The following is a description of a gene set: Examples of transcription factors whose activities are regulated by MAPK14 phosphorylation. from publication Turjanski AG, Vaqué JP, Gutkind JS (PMID 17496919) species: Homo sapiens Human Gene Set: TURJANSKI_MAPK14_TARGETS The mitogen-activated protein kinases (MAPKs) are a family of serine/threonine kinases that play an essential role in signal transduction by modulating gene transcription in the nucleus in response to changes in the cellular environment. They include the extracellular signal-regulated protein kinases (ERK1 and ERK2); c-Jun N-terminal kinases (JNK1, JNK2, JNK3); p38s (p38alpha, p38beta, p38gamma, p38delta) and ERK5. The molecular events in which MAPKs function can be separated in discrete and yet interrelated steps: activation of the MAPK by their upstream kinases, changes in the subcellular localization of MAPKs, and recognition, binding and phosphorylation of MAPK downstream targets. The resulting pattern of gene expression will ultimately depend on the integration of the combinatorial signals provided by the temporal activation of each group of MAPKs. This review will focus on how the specificity of signal transmission by MAPKs is achieved by scaffolding molecules and by the presence of structural motifs in MAPKs that are dynamically regulated by phosphorylation and protein-protein interactions. We discuss also how MAPKs recognize and phosphorylate their target nuclear proteins, including transcription factors, co-activators and repressors and chromatin-remodeling molecules, thereby affecting an intricate balance of nuclear regulatory molecules that ultimately control gene expression in response to environmental cues., and this is the list of marker genes: MEF2A, ELK1, ELK4, MEF2C, FOS, STAT4, ATF2, DDIT3, TP73 (tumor protein p73), TP53